The following is a description of a gene set: Human Gene Set: WP_KCNQ2RELATED_EPILEPSIES KCNQ2-related epilepsies species: Homo sapiens, and this is the list of marker genes: PRKACA, P2RY1, BDKRB2, CALM1, AKAP5, CSNK2A1, PPP3CC, AGTR1, KCNQ3, PPP1R10, STX1A (syntaxin 1A), ANK3, SCN1B, PLCG2, ITPR1, BACE1, KCNQ2, CHRM1, PRKCA